The following is a description of a gene set: Human Gene Set: WP_EFFECT_OF_DASATINIB_ON_THE_BCRABL_SIGNALING_PATHWAY Effect of dasatinib on the BCR-ABL signaling pathway species: Homo sapiens, and this is the list of marker genes: HRAS, SHC3, PTK2, SHC4, SOS1, GRB2, PIK3CA, HSPB2, SHC1, VAV1, HSPB1, KRAS, PIK3R1, AKT1, RPS6KA1, BCLAF1, MAP3K2, SPAG1, EIF4B, ABL1, BCL9, BCAR1, DOK1, GAB2, PXN, CRKL, NRAS, MEF2C, MAPK11, ATF2 (NCBI Gene Id 1386), MAPK14, SHC2, CBL, BCL2, BCR, MAPK3, AKT3, ARAF (NCBI Gene Id 369), BRAF, SRC (SRC proto-oncogene, non-receptor tyrosine kinase), AKT2, INPP5D, CRK, RAF1, MAPK1